The following is a description of a gene set: Reactome Pathway: Synthesis of bile acids and bile salts via 24-hydroxycholesterol electronically inferred by orthology from the curated human pathway part of: Synthesis of bile acids and bile salts species: Mus musculus This event has been computationally inferred from an event that has been demonstrated in another species.<p>The inference is based on the homology mapping from PANTHER. Briefly, reactions for which all involved PhysicalEntities (in input, output and catalyst) have a mapped orthologue/paralogue (for complexes at least 75% of components must have a mapping) are inferred to the other species., and this is the list of marker genes: Akr1d1, Cyp8b1, Slc27a5, Slc27a2, Akr1c14, Akr1c6, Akr1c13, Akr1c20 (NCBI Gene Id 116852), Cyp46a1, Akr1c18, Cyp39a1, Akr1c21, Amacr